The following is a description of a gene set: Mouse Gene Set: GOBP_RESPONSE_TO_GLUCAGON Any process that results in a change in state or activity of a cell or an organism (in terms of movement, secretion, enzyme production, gene expression, etc.) as a result of a glucagon stimulus. studied in species Mus musculus, and this is the list of marker genes: Stk11, Adcy8, Gnas, Srebf1, Cyc1, mt-Cytb, Ccna2, Cdo1, Cps1, Glp1r, Gjb2, Gcgr (NCBI Gene Id 14527), Abcb1a, Creb1, Rps6kb1, Glp2r, Hmga1, Cry1, Hmgcs2, Prkar1a, Pfkfb1, Pck1, Prkaca, Ass1, Gcg